Given this list of marker genes SCLY, GSTA3, CES1 (carboxylesterase 1), HRG, SERPINC1, ECHDC2, APOC1, ACSM2A, PRMT3, HSD17B6 (NCBI Gene Id 8630), UGT2B11, UGT2B7, GSTA2, ALDH1L1, C4A, SIX1, HMGCS2, here is a description of the gene set: from publication Yamashita T, Forgues M, Wang W, Kim JW, Ye Q, Jia H, Budhu A, Zanetti KA, Chen Y, Qin LX, Tang ZY, Wang XW (PMID 18316609) Down-regulated genes distinguishing hepatocellular carcinoma (HCC) samples positive for EPCAM from the negative ones. The heterogeneous nature of hepatocellular carcinoma (HCC) and the lack of appropriate biomarkers have hampered patient prognosis and treatment stratification. Recently, we have identified that a hepatic stem cell marker, epithelial cell adhesion molecule (EpCAM), may serve as an early biomarker of HCC because its expression is highly elevated in premalignant hepatic tissues and in a subset of HCC. In this study, we aimed to identify novel HCC subtypes that resemble certain stages of liver lineages by searching for EpCAM-coexpressed genes. A unique signature of EpCAM-positive HCCs was identified by cDNA microarray analysis of 40 HCC cases and validated by oligonucleotide microarray analysis of 238 independent HCC cases, which was further confirmed by immunohistochemical analysis of an additional 101 HCC cases. EpCAM-positive HCC displayed a distinct molecular signature with features of hepatic progenitor cells including the presence of known stem/progenitor markers such as cytokeratin 19, c-Kit, EpCAM, and activated Wnt-beta-catenin signaling, whereas EpCAM-negative HCC displayed genes with features of mature hepatocytes. Moreover, EpCAM-positive and EpCAM-negative HCC could be further subclassified into four groups with prognostic implication by determining the level of alpha-fetoprotein (AFP). These four subtypes displayed distinct gene expression patterns with features resembling certain stages of hepatic lineages. Taken together, we proposed an easy classification system defined by EpCAM and AFP to reveal HCC subtypes similar to hepatic cell maturation lineages, which may enable prognostic stratification and assessment of HCC patients with adjuvant therapy and provide new insights into the potential cellular origin of HCC and its activated molecular pathways. Human Gene Set: YAMASHITA_LIVER_CANCER_WITH_EPCAM_DN species: Homo sapiens